Given this list of marker genes Tarbp2, Ago4, here is a description of the gene set: electronically inferred by orthology from the curated human pathway species: Mus musculus Reactome Pathway: MicroRNA (miRNA) biogenesis part of: Gene Silencing by RNA This event has been computationally inferred from an event that has been demonstrated in another species.<p>The inference is based on the homology mapping from PANTHER. Briefly, reactions for which all involved PhysicalEntities (in input, output and catalyst) have a mapped orthologue/paralogue (for complexes at least 75% of components must have a mapping) are inferred to the other species.